The following is a description of a gene set: species: Mus musculus Mouse Gene Set: WP_FATTY_ACID_BETAOXIDATION Fatty acid beta-oxidation, and this is the list of marker genes: Tpi1, Eci1, Acsl1, Acads, Acat1, Lipe, Cpt1b, Hadha, Slc25a20, Gk2, Decr1, Gcdh, Hadh, Echs1, Cpt1a, Lipc, Acadm, Acss2, Chkb, Acsl6, Gk, Acsl3, Hadhb, Crat, Pnpla2, Acadl, Lipf, Gpd2, Acadvl, Lpl, Acsl4, Dld, Acsl5, Cpt2